The following is a description of a gene set: Human Gene Set: CREB3L4_TARGET_GENES Genes containing one or more binding sites for (CREB3L4) in their promoter regions (TSS -1000,+100 bp) as identified by GTRD version 20.06 ChIP-seq harmonization. from publication Yevshin I, Sharipov R, Kolmykov S, Kondrakhin Y, Kolpakov F (PMID 30445619) studied in species Homo sapiens, and this is the list of marker genes: HSD17B12, PHLDA1-AS1, CPSF4, AASDH, COPS2, EIF4EBP1, AGA, AIP, CREBZF, CCT7, JMY, FAM117B, TSPAN12, RIGI, SH3BGRL3, MFSD11, CMC2, KIAA1217, EMG1, PAXIP1, SLC9A3-OT1, MET (NCBI Gene Id 4233), ELMOD3, RN7SKP134, H3-3B, SLC12A9, KPNA3, PTEN, SNORD110, RNU6-1301P, PRR4, SLCO2B1, SAV1, COQ8B, PRH1, SMIM14, PRR7-AS1, PDXDC1, TMCC1, MSH3, PNPLA8, ZDHHC8BP, NUDT16, USP21, PIWIL4, TOM1L2, ZNF721, PLA2G6, PSMC4, SAMM50, RPL27, DYNLT1, ZC3H18, COPS8, CRELD1, MIF4GD-DT, SLC35A3, TIMM21, PRR15L, PTGER4, SF3B1, FOXP4-AS1, RCCD1 (RCC1 domain containing 1), EIF4A2, EZH2, OXA1L, LY75, TMEM232, ZNF616 (NCBI Gene Id 90317), SAP30L, TP53BP1, PTMA, H2AC12, RABEPK, SMARCE1, DBNL (NCBI Gene Id 28988), BSCL2, CSNK2B, BTAF1, BLZF1, CENPO, ZNF131, VPS18, PLEKHG2, FPGT, PPAN-P2RY11, LINC02756 (NCBI Gene Id 105369428), CDC25C (NCBI Gene Id 995), H2BC14, RAD52, RNF212B, RAB5IF, NFE2L3 (NFE2 like bZIP transcription factor 3), YIPF1, HOXB-AS3, MIS18BP1, ZNF668 (NCBI Gene Id 79759), PCGF1, SFPQ, RPPH1, ASPH (NCBI Gene Id 56921), PELP1, MIF4GD, DOCK5, ACAA2, PPIB, PRLR, ARHGEF2-AS2, R3HDM2, MAST4, MYG1, UBE2I, HELQ, RGS17P1, GTF2F1, DERL2, NEMP1, PHPT1 (phosphohistidine phosphatase 1), SHPK, ZNF740, HDDC3, ATXN2L, NFX1, SQSTM1, NAXE, PTGES2, SELENOK, PGRMC2, CHEK1, LMTK2, GTF2A1, CFAP61, XRCC4, SETD9, ZFP36, TNFSF9, SLC5A2, COL17A1, IBTK, TTC41P, ALDH6A1, LIN52, EIF3H, ALDH18A1, MYBPC1, CDK4, HMGXB3, C12orf57, PSMD8, RC3H1 (NCBI Gene Id 149041), FPGT-TNNI3K, QRSL1, EEF1AKMT1, TMEM167B-DT, LRRC45, TMEM165, MXI1, SNHG29 (NCBI Gene Id 125144), UNC93B1, UBL3, MGAT2, GTF3C4, LINC02331, HSPD1, NXT1, MIR6790, MAP1A, MSI2, SMARCAD1, CCDC186, ACTR3B, TRIM31, HIGD1A, ZKSCAN1, SAMTOR, CLCN6, IL6R, DRC3, CITED2, CBFB, H3C12, ILF2, PAFAH1B1 (NCBI Gene Id 5048), CNGA1, SH2D6, PPIC, PARP16, OXA1L-DT, ENSG00000265246, NUP93-DT, CCDC38, PAFAH2, C12orf60 (NCBI Gene Id 144608), ARID1A, SNX13, SFI1, NOP14, DDX23, PSD3, WFDC3, GDF9, SEC62, USP30, KLHDC10, CASP2, ANP32B, G3BP2, WBP11, STK3, STX12, BNIP3L, YJU2B, TPI1P2, HIF1AN, PPAN, SIPA1L1-AS1, ARPC4, FOXP2, SP2, PSMB7, PTCD1, ATP5PB, EVI5L, MBTPS1-DT, MED20, ECSIT, HERC1, FIP1L1, WDR74, WDR77, IFT57P1, PMEL, SH3RF2, MAL2 (NCBI Gene Id 114569), ATP6V1A, OAT, PRMT2, EIF4ENIF1, TIPIN, TM2D3, RPS29P16, DPH3, PDXP-DT, KAT5, LYRM1, OSER1, RBIS, ST7-AS1, SMARCA4, TRAF4, LRRC57, SFXN5, SNORD49B, ULK3, COIL, FNDC3B, RAB4B (RAB4B, member RAS oncogene family), ZNF282, ALAD, SETDB1, FLYWCH2, PI4K2A, CIRBP, KITLG, TEX30, SNHG21, CDCA7 (NCBI Gene Id 83879), CEP350, LRRIQ3, SUPT4H1, BRK1, SETD1B, WDR73, PRCP (prolylcarboxypeptidase), ATRAID, ARHGAP32, RASSF6, CD164 (CD164 molecule), CDCA2, C2orf76, ISCA1, ITPRIP, ARHGEF2, RHOF, NASP, WDR35-DT, PPME1, GNG5, PDE6D, TFB1M, AHCTF1, GOT2, NDUFS3, APTR, RAB3A, TICAM1 (TIR domain containing adaptor molecule 1), MAZ, CCNJL, ANP32E, PUM1, IQANK1, CTSH, PEX16, NUSAP1, APC, UBIAD1, RNF145, HECTD4, ZNF23, ST7-OT4, DHFR2, SNORA78, LINC02851, HSPBAP1, CARINH, RN7SL346P, COG4, RNFT2, FBXO8, WDR82, GRK4, PRKAG1, FAM210A, H2AJ, RPL7A, CHD2, LEAP2, LAS1L, DDX50 (NCBI Gene Id 79009), TGIF1, CCNG1, ZC3H10, ADK, MRPS30, ZFP36L1, MIA2, NAALADL2, AP2B1, PKP4, MAN2A1-DT, MRPL40 (mitochondrial ribosomal protein L40), HAUS2, AHSA1, RRBP1, CASKIN2, GFM1, FAM135A, FEM1B, NDUFB4, RSBN1L, FAM118B, ZNF425, ATG16L1, HOXC-AS2, EEF1A1-AS1, NRN1, SPRY1, FBXL20, H2BC9, ELP3, ZC3H7A, DCXR-DT, GEMIN2, ENSG00000282904, LACC1, FANCC, SRSF2, ISG15, H2AC11, CD55, NDUFV2 (NADH:ubiquinone oxidoreductase core subunit V2), GALNT7, GLCE, GINS4, RMI1, NGDN, LOXL3, NEDD1, RESF1, PSPH, LINC01719, ZNF689, CARD19, ACP1, NLK, EIF6, CCDC122, CARD8, ZNF77, TEPSIN (TEPSIN adaptor related protein complex 4 accessory protein), ERV3-1, SAP30L-AS1, NUMB, SNORD16, SMARCAL1, H4C13, CNIH1, GZF1, UBE2V1, GALNT10, COMMD6, UNK, RPL35AP13, FHL1P1, NFE2L2 (NCBI Gene Id 4780), SLC9A3-AS1, SDHC, MED1, RPP38, GAPVD1, DDX18, STAT3, TNRC6A, MRFAP1L2, BRD2, CALM3, RABGEF1, SNORD15A, NBAS, AFG3L2, ACTR8, PELP1-DT (PELP1 divergent transcript), REPIN1, ENSG00000227218, ZNF343, ATF6, GATAD2B, KCTD7, ENSG00000263280, MFSD4B-DT, RTRAF, ENSG00000223446, RAD54B, TTC8, KBTBD4, GPANK1, SURF6 (surfeit 6), CCDC25, DDX59, ZBED5, SCP2, CENPX, MATR3, YTHDC2, THAP6, ERI2, CETN3, FAM187A, SAXO2, SNORD54, SPNS1, DCAF7 (NCBI Gene Id 10238), SCAPER, COL1A1, PIMREG, UCHL3, SLC39A8, KDM4B, MTERF4 (mitochondrial transcription termination factor 4), ZNF117 (zinc finger protein 117), SLC35B1, MAP4K2, COX7C, LINC01763, SCARNA17, CCN2, CLDN7, MSMO1, MFSD4B, ZNF276, USP12, SLC12A6, CLNS1A, MCRIP2 (NCBI Gene Id 84331), MAD2L1-DT, DIP2B, RNU6-952P, GPR155-DT, H2BC11, SETD6, ARHGAP26, USP1, WDR55, VPS33B, PHAX (phosphorylated adaptor for RNA export), MRPS23, RPL17, USP35, CCDC7, ZBTB10, FBXO28, FAM83C-AS1, ZBED5-AS1, HNRNPK, ACSL1, PSMG4, AKR1C3, MRPL39, RTTN, DNAJC16, TBCCD1, ZDHHC5, ZBTB43, BPTF, RAB10, TMEM65, TSR1, NEDD4, TBX3, CDK8, C2CD3, SCLY, KDM2B, WDR35 (WD repeat domain 35), CCNB2, ALG10, RPL10, SDE2, ZDHHC17, DYRK3, SMG1, RIOX1, EFL1, POP5, LRRC40, KAZALD1 (NCBI Gene Id 81621), LINC01635 (NCBI Gene Id 101928043), SKIC8, NUB1, MEST, SCOC, KNSTRN, PRADC1, VPS52 (NCBI Gene Id 6293), KIF9, OSER1-DT, SNORD58B, SLC7A6OS, DST, ATG101, BCL2L15, GOLGA5, SLC38A9, KDM4A, EBAG9, FLYWCH1, ATP5F1A, CEP95, AURKA, MLEC, UBE3D (NCBI Gene Id 90025), KCNAB2, DHPS, ZNHIT6, TBC1D14, SPTBN4, SLC18B1, REPS1, MSANTD4, PTBP1, RNU2-17P, CLTC, RIPK1, MUC1, SMIM31, GFI1, ESYT1, KMT5A, ID2-AS1, LINC00910, SLC16A6, EXOC5, SLC52A3, ZNF394, PTPN4, BLVRB, MGST3, VPS9D1, STX19 (NCBI Gene Id 415117), MTMR12, ZBTB45, VIPAS39, GOT1, BET1L, ATP5MC1, RBM22, PUS1-AS1, RNF5, PLPP6, USP34, PUS7L, ATP6AP1L, NOL8, SMAD3-AS1, NCL, MAPK14, NAB1, RAB5A, MPC1, BMAL1, ZBTB11, AFF1, SF3A2, METTL8, SPATA17, MIA2-AS1, PPM1D, TYMS, OIP5, RAB4B-EGLN2, SZRD1, PDHB, RITA1, GGA2, ESRP2, PRMT7, MAN2C1, YWHAQ, RNF44, FOXA2, MIR4664, PRELID2, ZBTB20, ZNF384, FTO, KANSL1, TPGS1, DGAT2, ST7L, DPM2, DRG2, CLPTM1L, MAN1B1, XPO5, COMMD4, CPT2, ARL4A, TMEM209, FUT11, NUTF2, RALB, CSF1, USP37, ACOT11, ARGLU1, OAZ2, ID2, NANS, SLC25A46, NDUFC2, GSK3B, PUS1, TTF2, CSAD, RANBP2, CIMAP1B, THRB-AS1, FBXO15 (NCBI Gene Id 201456), EDC3, RABGAP1L-DT, EPS8L3, PAK6, NOX1, OSBPL3, TM9SF4, LCORL, FDPS, FAM201A, SSU72, GCDH, TRA2A, SNORA24, THBS4, PSME3, CTNS, RDH10, TMEM106C, BCAR3, TMED5, FBXO38-DT, LINC03015, PPIA, ZNF391, SNHG9, SLC25A36, SLC36A1, NDUFAF4, ERVK3-1, XXYLT1, PPP2R3B, SNORD18A (NCBI Gene Id 595098), ZNF576, POLR2D, YEATS4, COA6, NME7, RNY1, RPL15, USP15, SLC7A7, MARCHF3, NKIRAS1, PSMC2, DDX17, STXBP5-AS1, SLC50A1, ALG8, AIRIM, L2HGDH, P4HB, RGL1, NKIRAS2, ERCC5, MAST4-AS1, IRF2BP1, PRR5L, RAB14, MAP4K3, DRAIC, RPL10A, POT1-AS1, SP1, TMEM259, TRIO, RAB5B, CASP9, PLK3, TAFA2, TRIM52-AS1, LINC02609, RFC5, RNU6-502P, RPGRIP1L, SNORD43, RNVU1-6, ENSG00000226097 (NCBI Gene Id 101927769), ZRANB3, WDR62, TSPAN1, COX14, SNHG8, RPS20, MTHFD2, RNU2-2P, ZNF181, SNRNP70, SNX11, RNU6-2, PLEKHA8P1, LTBP1 (latent transforming growth factor beta binding protein 1), PSMF1, DNTTIP1, ATL2, PHYKPL, C11orf98, NCOA4, KIF27, UTP3, PGP, RNF207-AS1, CIB1, S100A16, HS1BP3, DICER1-AS1, PIGO, LINC01588, C1orf74, LINC01144, PMVK, TMEM87B, GPAM, PITPNB, PPA1, LLGL2, ATAD3A, RNF32, ENSG00000239142, PEF1-AS1, BCDIN3D, BECN1 (NCBI Gene Id 8678), ZFP90, FGD6, SLC49A4, ITGA6, PIGG, NDUFS4, PSMA5, RUFY1, H3C10, DNMT1, RAD17, CRNKL1, CHMP1A, USP53, RNU5E-6P, NUP93, TUBGCP5 (NCBI Gene Id 114791), DNAAF5, MRPL51, KLHDC2, CCDC18-AS1, ELP5, PPIL4, LINC-PINT, RIC8A, COX6B1, RRM1, NIPA1, SLC35E3, COA6-AS1, TNPO3, PRCC, EIF3E, PHB2, DEPDC5, CYP26B1, CMC1, FUT4, PAXBP1, GLO1, HSP90B1, MINDY2, AREG, PPP6R1, TRA2B, CCT6A, ZNF79, ZBTB14, KLHL18, ZNF555, AAAS (NCBI Gene Id 8086), REXO5, RTN4IP1, DPH2, ABI1, TCTA, SNX12, BCKDHA, BRIX1, SPRED2, GAS5-AS1, AGPAT1, H2AZ2, BAZ2A, AURKB, ZWINT, COQ7, NDUFS2, GBF1, TMEM267, TXLNA, TMEM167B, ARL1, RPS24, UBN2, VOPP1, SCAMP5, ARPC4-TTLL3, PDXP, MAIP1, ENO1 (enolase 1), TTC5, DERL3, ENPP3, CCND2, DNAJA2-DT, AP5M1, MBD1, EAPP, TTC28-AS1, ZNF639, HSPE1, TM9SF1, CNPY2, CNOT1, PNPLA6, WNK1, MTHFD1, ATP6V1D, SRSF6, CRKL, RBSN, SRD5A3-AS1, LINC02405, MVD, FGD5-AS1 (FGD5 antisense RNA 1), HOXA1, NOL11, SGSM2, SECISBP2L, SNORD49A, TIMM10, SPRY4, BAP1, TIMM22, MIS12, SF3B3, RPL36AL, DMXL2, GPRC5A, AKAP8L, IRGQ, LTBP3, GPR155, CAPG, LINC02924, USP45, ARHGAP11B-DT, RPL21, BIRC2, RNA5SP146, HAX1, CENPP (NCBI Gene Id 401541), CYP2S1, SRA1, CHAC1, HNRNPC, SMARCA2, PRPF19-DT, CTNNA1, FLAD1, XRCC5 (X-ray repair cross complementing 5), ZC3H15, NUP35, PINX1, PCF11, TMEM14B, GCFC2, HERC4, USE1, CEP164, TMEM69, SREK1, BTBD10, MINDY2-DT, CCDC134, SNAI3-AS1, CLCN3, GLG1, RPS23, COX7A2L, LRRC28 (NCBI Gene Id 123355), CSTF1, RAB37, PSMD3, MTHFR, PTRH2, MFSD5, GUK1, MTRFR, AMN1, AGBL3, MBTPS1, COX19, HACL1, KRT8, ZFYVE26, PRPF19, COPZ1, MAGEF1, SPRING1, LIMD1-AS1, STAT1, CRYZL1, MIR4521, USP54, KDM2B-DT, LINC01003, R3HCC1L (NCBI Gene Id 27291), PICK1, CA11, ACKR2, PBLD, EIF3B, AADACP1, JMJD1C, CARS2, CCDC86, ANKRD18A, PDSS2, PHF7, H2AC14, MRPL52, SLC25A42, PHLDA1-DT, ITPRID2, ZFP64, SRRT, GDAP1, GPBP1L1, CUEDC2, COPS8-DT, AK6, RNF207, LINC01089, CERNA3, AMDHD1, METTL26, LMNB1-DT, ENSG00000200288, CDK12, UNC13D, ARHGAP5, WHRN, CISD3, PRR13, ASB8, NCEH1, MCM6, COMMD8, C3orf52, NUDT16-DT, CYB5A, ARRDC4, ZC3H4, TAS2R14, PSMD6, CD24, NUDC, TBX6, MED23, PIERCE2, FAM200A, CSNK2A1, ZNF564, CAPZA2 (NCBI Gene Id 830), TMPO, BAG6, ZNF785, COQ7-DT, CATIP-AS1, SNX8, PRR7, HOXB3, NAGK, DMAC2L, DET1, LINC03014, CYSRT1, CCNA2, RPL3, RNY3, AATF, PLAA, DCUN1D3, DOHH, VWA8, HTATSF1P2, FNDC3A, MRPS30-DT, FOSL1, PRPF8, THEM4, PCSK9, ROCK2, SACM1L, CCT4, TM7SF3, FOXP4, VPS33B-DT, POT1 (protection of telomeres 1), CLIP1, USP38, CTDNEP1, DDX54, SPCS3-AS1, STX8, BAZ1B, CCDC183, TMEM222, LIPE, PIM1, TMEM14B-DT, CCDC103, SKA3, SYVN1, DBI, NFKBIZ, ITK, SRSF11, PHLDA1, ISOC1 (isochorismatase domain containing 1), MRPS18C, MAP3K6, TMEM115, SNORA74D, RPS2 (NCBI Gene Id 6187), LGR4, CIMIP6, IDE, ANAPC1, TADA3, RPS19, MYO1D, NDUFC2-KCTD14, PER1, LINC00963, ECE1, NIPAL1, MRPS31, VPS28, COMMD1, METTL3, R3HDM1, DCP1A, DHDDS, GLYCTK, SRP54-AS1, ECE2, RN7SKP192, NPM3, VPS45 (NCBI Gene Id 11312), EID2B (EP300 interacting inhibitor of differentiation 2B), DUSP19, ASRGL1, INAVA, PDK1, HAUS6, SNHG22, BZW1, PPP5D1P, RLIG1, RRM2, NEAT1, PLEKHJ1, PSMB10, GULP1, GRHL3, B9D1, METTL16, FAM120AOS, RASA1, H2AC8, FAM47E, ADGRG6, DDX5, CENPN, EED, IER3, TRIM52, GSK3B-DT, RPL24, RHOC, CDH11, SSBP2, LINC02482, XPOT, HBP1, ULBP3, KLF5, RAB21, ALG3, MRPS31P4, KIF3A, LMNB1, BCL2L14, PIK3C2B, SLC66A3, MRFAP1, DNAJC2, ASH2L, N4BP2L2, DENR, DNAJA2, CNOT9, CHD1, EPCAM, GCNT3, NDUFAF4P1, CA13, IRAK4, RNVU1-2, SMG1-DT, ACER2, NUP85, RABGAP1L, LIPE-AS1, SET, PARP2, WBP1, FOXN2, H2BC8, GOLGA7, CYTIP, CCPG1, NEK2, PTPRO, RNY4, POMP, RNMT, THRAP3 (thyroid hormone receptor associated protein 3), ZSWIM4, ZCCHC8, MED22, GRHPR, VMP1, TSN, MPHOSPH9, PFDN4, ENTPD1-AS1, AMACR, SIPA1L1, FKBP2, LMO7, TBC1D22A, PPP1R37, PLXDC1, POLH, MRPL9, GHET1, KIF2C, ARPC5, GAS5 (growth arrest specific 5), UBE2C, PTRHD1, RNU1-117P, RAD1, HPF1, TCERG1, ATAD3B, ABHD11, ENPP4, ZNF322, DSG1-AS1, EXOSC5, INTS2, DGCR8, OAZ3, TYW5 (NCBI Gene Id 129450), NKTR, DCXR, LINC02361, GEMIN8, RABGAP1, NDUFAF8, GARIN5A, SLC7A11, LINC02253 (NCBI Gene Id 107984764), CAPN8, POLD2, TIGD6, PKNOX1, DCAF17, SRRM5, MRPS15 (NCBI Gene Id 64960), TTC23, WWP2, UTP23, EFTUD2, MIR194-2HG, BMPR1A, SARAF, NET1, SF3B6, VSIG10, ZNF646, NPC1 (NPC intracellular cholesterol transporter 1), CLTB, EIF2S1, RPS3, HADH, DMAP1, NLN, RNF32-DT, ENSG00000273162, RACK1, PHKB, AARS2, RPS21, CACYBP, ARHGAP11A, TBL1XR1, PKM, GRHL3-AS1, TIMM44, MBNL1, TSEN54, ITSN1, RAD51, ADPGK, OLMALINC, HNRNPA3, RPL17-C18orf32, INKA2, ZFAND3, CYP2J2, GPR161, EEF1A1, ST7, BTD, ITPKA, PCBP2, SNHG15, TNRC18, KLC2, CNPY3, CDCA7L, DIAPH1, SMARCAD1-DT, FAM53C, PYM1, VTA1, PPIL2 (peptidylprolyl isomerase like 2), MAN2A1, MCM5, PDE7A-DT (NCBI Gene Id 118568829), PINX1-DT, ALS2, ENSG00000187951, DGKA, HOMER1, SLC41A2, DIS3L2, RNASEH1, RHBDD1, GOLGA3, ESRP1, SDHAF1 (NCBI Gene Id 651076), ZNF317, FBXO16, RBM4, NSUN3, DHFR, RAD51-AS1, PWWP2A, STRN3, DEPDC4, EFCAB2, CPLANE1, HACD3, LCA5, LY75-CD302, RHOA, SLC5A6, CDKN1B, SAR1B, GPATCH2, ETFBKMT (NCBI Gene Id 254013), MMAB, CFDP1, FUZ, LARS1, HTATIP2, ENSG00000263011, GRAMD2B, GOT1-DT, LRPPRC, MNS1, FERMT1, IFT74, HMGN4, EMC10, PROS1, LRRC14, MED15, SNORA73A, EDRF1-DT, RTN4, PDE7A, NR2C2, RPL7, KCTD21, PTOV1, FNTB, DIXDC1, CR2, TTC1, HIRA, RIOK1 (NCBI Gene Id 83732), BYSL, HSPE1-MOB4, H2AZ2-DT, PARN, GCN1, SH3YL1, TAF9, ZNF628, CDK2AP2, OSBPL10, CASP6, MAN1B1-DT, UQCRQ, REXO4, PTGES2-AS1, HAT1, PEF1, RPUSD4, ANKRD31, SH3D19, INO80, GLUL, UBR5, LRRC66, MTIF2 (mitochondrial translational initiation factor 2), RPS18, ZNF860, STOML2, NOS2, OSBP, DDX6, MVK (mevalonate kinase), RBM47, PCGF6, NELFA, TCF3, GUSB, EFCAB14 (EF-hand calcium binding domain 14), PLBD1, EGLN2, PCNA, DUSP3 (dual specificity phosphatase 3), DICER1, NAA50, ZZZ3, KCTD9, ARHGAP11A-DT, DDX41, SRP54, PTPRK, ZEB2, ZNF688, CRTAP, MUC13, MATCAP2, LSG1, ERC1, RN7SL181P, FBXO38, ZNF747-DT, CFAP52, YBX1, SAE1, CSNK2A2, UGP2, DUSP10, MED26, TRIB1, TMC1, SNORD95, MARCHF7 (NCBI Gene Id 64844), GINS1 (GINS complex subunit 1)